The following is a description of a gene set: The process in which a solute is transported from one side of the vacuolar membrane to the other. species: Mus musculus Mouse Gene Set: GOBP_VACUOLAR_TRANSMEMBRANE_TRANSPORT, and this is the list of marker genes: Slc15a4, Slc30a4, Slc30a3, Slc48a1, Slc46a3, Slc17a9, Slc30a2, Mfsd1, Ap3d1